Given this list of marker genes USP30, PPP2R1B, PREP, MTMR9, SH3BGRL3, CYB5R4, EPS15, IGFBP5, MARCHF7, TRERF1, CABYR, RBM11, ZNF800, FAM47A, NDST3, SENP1, METAP2 (methionyl aminopeptidase 2), CSRNP3, PHETA1, FAM177B, BEND4, IRF5, AZIN1, BOC, ABCA1, CD302 (NCBI Gene Id 9936), PFN2, TMEM140, FAM47B, TMED7 (NCBI Gene Id 51014), NUFIP2, ANAPC16, PHF2, ZNF594, RMDN1, BRD10, LY75-CD302, CRB1, NDUFA5, FABP7, APBB2, GPR85, RBM39, PTPN5, FZD5, STK39, SSR1, EDN3, GALNT6, FMR1, BAIAP2, RAD23B, MID1, MEF2C, NFE2, RPL7L1, IL6ST, DIP2C (NCBI Gene Id 22982), URI1, SEMA6D, NECTIN3, NR3C1, ABCC4, here is a description of the gene set: species: Homo sapiens Genes predicted to be targets of miRBase v22 microRNA hsa-miR-744-3p in miRDB v6.0 with MirTarget v4 prediction scores > 80 (high confidence targets). from publication Chen Y, Wang X (PMID 31504780) Human Gene Set: MIR744_3P